Given this list of marker genes Sirt1, Mir207, Letm1 (NCBI Gene Id 56384), Nherf2, Natd1, Eef1d, 1700113A16Rik, Sec61a2, Tmem87b, 1810055G02Rik, Zfc3h1, Map4, Rusc2, G3bp1, Rer1, 3110040N11Rik, Ugp2, Psap, Fkbp4 (FK506 binding protein 4), Atxn7l3, Rc3h1, Nadk, Uba52, Mbd3, Hsp90ab1, Poldip3, Lbh, Zfp646, Ttc7, Srsf9, Golga2 (NCBI Gene Id 99412), Ugdh (NCBI Gene Id 22235), Slc25a4, Esyt2, Tmem175, 4930502E09Rik, Map2k2, Erc1, Rpl12, Sema4b (NCBI Gene Id 20352), Dapk3, Paip2, Ptgs2, Aldoa, Dnaja1, Anapc5, Sp1, Adpgk, D2hgdh, Rplp0, Rsrp1, E130311K13Rik, Mrpl2, Nfs1, Man1a, Rab21, Tasp1, Id3, Rcc1, Gm13267, Uspl1, B4gat1, Tnrc6c, Slbp, Tmem116, Mir8105, Mfsd10, Dnajb4, Btg1, Tab1, Smurf2, Prmt5, Edem2, Hmga1, Wdr43 (NCBI Gene Id 72515), Mthfd2 (NCBI Gene Id 17768), Id1, Amh, Pip4k2b, Stmp1, Sun2, Tpi1, Pradc1, Fbxo31, Pdcd6ip, Nprl3, Sec62, Mif4gd, P2rx4, Ankrd52, Cirbp, Ptbp1, Gm34106, Csrnp2, Rara, Grb2, Ccn1 (cellular communication network factor 1), N4bp3, 4833418N02Rik (RIKEN cDNA 4833418N02 gene), Taf4, Slc9a1, Smarcc2, Nop56, Usp19, BC031181, Memo1, Commd10, Junb, Arhgap26 (NCBI Gene Id 71302), Col5a1, Cd24a, St3gal3, Hexd, Txn2, Npcd, Knl1, Thap7, Erbb3, Gm16998, Cbx5, Gm10459, Nedd9, Rps20, Dalrd3, Hdac3, Sdhaf2, Actb, Atp2a2, Swi5, Tob1, Setd5, Gm17501, Mm2pr, Fam216a, Tlcd1, Pakap, Pcolce, Gm10069, Dennd6b, Lats1, Ogfod3, Txnrd1, Dgcr8, Card19, Sec63, Mgat3, Dus3l, Cnpy3, Arf4, Pcif1, Tamalin, Myl12b, Derl2, Rell2, Mcl1, Sacm1l, G3bp2, Gt(ROSA)26Sor, Dnajc5, Flywch1, Rps6, Oard1, Tnfsf9, Pcmt1, Gpx1, Fendrr, Ptpn2 (protein tyrosine phosphatase, non-receptor type 2), Nubp1, Gmnn, Brd2, Smim19, Sanbr, Fubp1, Gsk3b, Esco1, Chkb, Ube2z, Morn1, Rnu12, Rbm22, Zfp36, Selenoo, Polg, Atxn2, Zfp668, Srd5a3, Dusp1 (dual specificity phosphatase 1), Rpl30, Arid5a, Srsf6, Zfp866, Ankhd1, Dnajb12, Gm2a, Mgat1, Foxf1, Jmjd1c, Ncoa7, Zfp707, Mmp11, Coq9, C730034F03Rik, Agpat2, Usp10, Appbp2, Myo1c, Tuba1a, Rpl3, Snord43, Arf4os, Ctnna3, Amotl2, Iba57 (IBA57 homolog, iron-sulfur cluster assembly), Zfp513, Ccdc138, Gcn1, Gpr19, Smarcb1 (SWI/SNF related, matrix associated, actin dependent regulator of chromatin, subfamily b, member 1), Hbegf, Nol7, Nemp1, Mrpl58, Appbp2os, Gak, Ccdc88a, Nab2, A330009N23Rik, Adal (adenosine deaminase-like), Gpn3, Dhx9, Vars1, Gltp, Fus, Hnrnpa1, Lrsam1, Ciapin1, Mirlet7i, Polrmt, Mir5122, Ube2g2, Tmco3, Stat5b, Plau, Lcmt2, Vamp5 (NCBI Gene Id 53620), Pygo2, Gm24016, Arhgap19, Dhrs11, Odf2 (outer dense fiber of sperm tails 2), Sppl3, Kdm4b, Eno1, Ttc17, Mis12, Gcat, Cbx6, Snord110, Prx, P4ha1, Grina, Zhx1, Ppp4r1, Cdr2l, Fosl2, Efcab2, Ptgs2os, Nek2, Immt, Twsg1, H3f3b, Gm16576, Dcun1d2, Erp29, Ahnak, Puf60, Thap2, Zzz3, Ier5l, Tsc22d1, Ddit4, D930048N14Rik, Col1a1 (NCBI Gene Id 217123), Rassf1, here is a description of the gene set: Mouse Gene Set: HEXIM1_TARGET_GENES Genes containing one or more binding sites for (Hexim1) in their promoter regions (TSS -1000,+100 bp) as identified by GTRD version 20.06 ChIP-seq harmonization. from publication Yevshin I, Sharipov R, Kolmykov S, Kondrakhin Y, Kolpakov F (PMID 30445619) studied in species Mus musculus